The following is a description of a gene set: Reactome Pathway: Class I peroxisomal membrane protein import part of: Protein localization electronically inferred by orthology from the curated human pathway species: Mus musculus This event has been computationally inferred from an event that has been demonstrated in another species.<p>The inference is based on the homology mapping from PANTHER. Briefly, reactions for which all involved PhysicalEntities (in input, output and catalyst) have a mapped orthologue/paralogue (for complexes at least 75% of components must have a mapping) are inferred to the other species., and this is the list of marker genes: Fis1, Acbd5, Pex11b, Gdap1, Pex13, Atad1, Pex26, Pxmp2, Pex12, Abcd1, Pex19, Abcd2